The following is a description of a gene set: studied in species Mus musculus Genes negatively differentially expressed in cell type: cDC1 (conventional dendritic cell type 1) upon treatment with cytokine: C5a in mouse lymph nodes in vivo. Mouse Gene Set: CUI_CDC1_C5A_RESPONSE_DN Cytokines mediate cell-cell communication in the immune system and represent important therapeutic targets. A myriad of studies have highlighted their central role in immune function, yet we lack a global view of the cellular responses of each immune cell type to each cytokine. To address this gap, the authors created the Immune Dictionary, a compendium of single-cell transcriptomic profiles of more than 17 immune cell types in response to each of 86 cytokines (>1,400 cytokine-cell type combinations) in mouse lymph nodes in vivo. A cytokine-centric view of the dictionary revealed that most cytokines induce highly cell-type-specific responses. For example, the inflammatory cytokine interleukin-1β induces distinct gene programmes in almost every cell type. A cell-type-centric view of the dictionary identified more than 66 cytokine-driven cellular polarization states across immune cell types, including previously uncharacterized states such as an interleukin-18-induced polyfunctional natural killer cell state. from publication Cui A, Huang T, Li S, Ma A, Pérez JL, Sander C, Keskin DB, Wu CJ, Fraenkel E, Hacohen N (PMID 38057668), and this is the list of marker genes: Dusp1, Rab11fip1, Fos (FBJ osteosarcoma oncogene), Tsc22d3, Klf6, Pmaip1, Fosb, Klf2, Jun, Klf4, Atf3